Given this list of marker genes Casz1, Dlx1, Sox9 (NCBI Gene Id 70015), Sox8, Shh, Cntf, Six3os1, Dlx2, Notch1, here is a description of the gene set: species: Mus musculus Any process that modulates the frequency, rate or extent of photoreceptor cell differentiation. An example of this process is found in Drosophila melanogaster. Mouse Gene Set: GOBP_REGULATION_OF_PHOTORECEPTOR_CELL_DIFFERENTIATION